Given this list of marker genes CCL7, POLR1D, B3GNT2, SSBP2, VIRMA, PEBP1, PRC1, GABARAP, FURIN, ZMYM2, NSMCE2, ORMDL1, TRDN, HS3ST4, UTY, RO60, HMGB1, WIPF2, SIGMAR1, TM4SF1, MPP1, MTUS1, TBX10, ZMYND11, AEBP2, FCGR3B, AMIGO1, ZMAT4, DNAJC16, FCGR3A, DCDC2, TSN, LRP8, PPP6C, EXOC4, UBE4B, YWHAG, PDCD4, APOC4, here is a description of the gene set: species: Homo sapiens Human Gene Set: MIR6798_3P from publication Chen Y, Wang X (PMID 31504780) Genes predicted to be targets of miRBase v22 microRNA hsa-miR-6798-3p in miRDB v6.0 with MirTarget v4 prediction scores > 80 (high confidence targets).